Given this list of marker genes IDE, VTRNA1-3, POLR2J3, RNA5SP181, SERTAD4, PDE4B, PROSER3, BORCS5, PPP2CA (NCBI Gene Id 5515), BVES, POLD1, BEST1, CD84, SLC25A20, RNU6-622P, HMCN1, NAALAD2, OR2F1, LTBP4, LINC02426, TMEM147-AS1, FUT6, GAS2L3, PTK2, CPVL-AS2, CYP2AC1P, ERCC6, ANKRD28, TMEM17, ANKRD16, KRT222, CSNK1G1, SLCO6A1, CPD, MIR3912, TSPAN17, DNAJB6, STARD6, RAB37, ACHE, PILRA, GPSM2, NLRP2, RIN1, SLC7A4, NUP210L, USP32, SHCBP1, DYNLT2, APP, VPS26C, FAM204A, ZNF407, LRRC23 (NCBI Gene Id 10233), DCTN4, RPL36AP20, FBL, ELOCP18 (elongin C pseudogene 18), COL16A1, ARL16, BDNF, GPI, SH3BP2, SHARPIN, MT-ND4L, SMARCD2, PPP4R1L, SNCA, MIR5087, RHOBTB1, KRT17, ABCB9, XPA, NEK3, C5orf58, NDUFB3, FLII, RNU6-464P, CD2AP, HSH2D, ZNF292, CTPS1, SGIP1, SCARF1, CD63, FEM1B, PPP1R15A, LRRC34, RPL29P2, SLC39A13, CTNNA1, RC3H2, RAB31, DSG4, LOH12CR2, PDLIM1, MT-TR, RUSC2, SLC7A11-AS1 (SLC7A11 antisense RNA 1), HSF5, RPS11, ACTN2, RGS8, SCTR, CCDC185, RPL10P13, RPL7P54, NBPF1, MIR6074, MIR4481, TROAP, STRN4, SCIRT, PIDD1, NCMAP, CDK5RAP2, MIR302A, LINC02243, TCEANC, BUD31, CTHRC1P1, CDC42, EIF3K, ZNF223, TSEN54, MEF2C-AS1, SNORA61, PRKN (NCBI Gene Id 8004), WFIKKN2, GSG1L, POLK, ENSG00000261924 (novel transcript, antisense to RPTOR), H1-5, HIGD1C, YIPF3, SLC25A45 (solute carrier family 25 member 45), KLC4, CTBP2, TIE1, MAN2A2, MLST8, MRPL58, TMEM132B, ELOVL6, ALAS1 (5'-aminolevulinate synthase 1), RBFOX2, ZNF322, IGHVII-44-2, ITGB4, SCAF8 (NCBI Gene Id 22828), RNU6ATAC38P, TIGD2, FTCD, NUP85, RAD23A, LINC00343, ZNF461, DPF1, ENSG00000260378, ENSG00000221332, CLIC5, POLR2I, USP11, ZNF17, TRAV6 (NCBI Gene Id 6956), CCND2, MYO19, LINC01886, MIR367, MICAL3, UBA5, CNNM1, STAG3, UBE2V2, PRR29-AS1, LINC01614, PPP1CC, GPR183, TPH2, PLD1, ELMOD2, RN7SL284P, C19orf47, NR2C2, BACH1-IT2, DQX1, LINC00534, CPSF3, ANXA4, RFT1, ZNF320, FMR1-IT1, TMEM86A, TROAP-AS1, NT5C2, UBAP2L, GNLY, MT-ND4, BLVRB, UTP6, UFSP2, CFAP298, HNRNPA1P18, DNAJC8, MYO1E, CHCT1, SSBL2P (small RNA binding exonuclease protection factor La like 2, pseudogene), RNVU1-22, TMEM44, UBB, IRF5, MAZ, AKR1B1P7, CRAT, CREB3, MIR641, GJC3, SPX, PHB2P1 (NCBI Gene Id 650109), BNIPL (NCBI Gene Id 192667), HNRNPH1, DPP8, LTBP2, VCF2, ADRA2A, MYRIP, CNOT8, TNFAIP6, ZNF225-AS1 (NCBI Gene Id 100379224), SLC5A9, DBNL, TOMM40L, SUPT20H, FAM184A, B4GAT1, CLYBL, RNU7-80P, NFATC4 (NCBI Gene Id 4776), ACAD9, STARD13, RNA5SP112, PRDM16, EMD, AGPAT4, ENSG00000204117, HDAC8, EHMT2, MED15, TAFA2, RPS5, SNORD116-3, PKN3, ANO10, AOAH, CD2BP2-DT, SNORA70, ADD1, MTATP6P31, MIR545, GSK3A, FAM3B, DDX39B, ATF7IP2, MAP3K7CL, ZNF646, EGLN2 (NCBI Gene Id 54750), GFRA3, NFASC, RPL10, NEUROG3, SLC24A1, CABP1-DT, EML2, SFI1, MIR4466, RPS3AP4, SDCCAG8, CABYR, RPL17P50, RGL2, LAMTOR3P1, CUZD1, PARP6 (NCBI Gene Id 56966), RNU6-481P, MYCBPAP, GTPBP2, KDM2B, PCK1, PLEKHG2, RN7SKP132, PGBP, PTGES3L-AARSD1, TNNT2, ENO1, PTPRB, DEGS2, CERK, FABP5P5, ZNF593 (NCBI Gene Id 51042), CALML6, WDR26, PTCD3, PELATON, MIR548AP, RNA5SP307, MAP4K5, SNRPGP11 (small nuclear ribonucleoprotein polypeptide G pseudogene 11), BMP1, DLGAP1-AS3, ZNF284, NCF4, CREBRF, EAF1-AS1, SEC16B (NCBI Gene Id 89866), DPPA3P3, SLC16A12, LINC00184, TMEM249, NKIRAS1, LDLRAD4, ABCA4, DLG1, TMEM116, SLC35E4, PRSS3, SLC18A1, TRAJ60, SNORA73A, MIR320B2, SLTM, SOBP, PKN1, UBE3AP2, POU2F1, MYLK3, MEF2A, ZNF775, SELENOW, ZBTB17, SERF2, ANKRD26, NCOA4, ATG7, FGF11, RN7SL789P, RNA5SP442 (NCBI Gene Id 106480768), CCR5AS, ATXN2, CYLD-AS1, LINC01344, THY1-AS1, SGCZ, MIX23P5, MFSD5, DTNBP1, MIR302D, TTC39C, ATP5MFP1, SLC17A7 (NCBI Gene Id 57030), TM9SF2, MAD2L1BP, MYEOV, STARD9, PSMC1P10, DRAIC, POLR1C, XPNPEP1, TCEAL6, DHX38, FCHO1, IL13RA2, STAT3, CEACAM4, CCNE1, IGHV3-30-2, NPM1, UQCRBP2, ICMT-DT, PBRM1, RGS6, CD27, USF1, SLC9A5, MIR302C, FAM180B, MYCBP, RNU6-1039P, SNRPA, KLC1, PLCE1P1, NKX1-2 (NK1 homeobox 2), TARID, CASC2, TECR, FCGR2A, B4GAT1-DT (B4GAT1 divergent transcript), PTGES3L, RPS6KA6, WNT11, RPL23AP72, AZIN2, CLEC1A, MT-TF, TRPV2, DNM1, CYP2E1, FMR1, MIR6783, RNU6-1019P, RNU1-133P, YWHAH, MRPS31P5, METTL17, SLC25A19, HMGN2P46 (high mobility group nucleosomal binding domain 2 pseudogene 46), FNDC11, GPC5-AS1, IL24, ELF3-AS1, USP54, RPL35AP36, MIR1268A, SNORD123 (small nucleolar RNA, C/D box 123), CHORDC1P4, C1orf232, TTLL4, RHEB, RNA5SP493, CGRRF1, ITGB3BP, RNU6-1115P (NCBI Gene Id 106480639), DYRK2, RPS27P7, C11orf58, SNORD114-25, SYNGAP1, SARDH, TMEM190, METAP1D, NACA, FAM114A2, LINC02312, POU3F2, CPAMD8, FCSK, SPPL3, CT62, DNAH14, GNAS, ENSG00000207502, RNU6-864P, SDS, RNU6-808P, BCAS3, MIR4480, VANGL1, TANC1, HDDC2, HRG-AS1, NPM1P26, RP1L1, LINC01485, DNMT1, GNG4, MN1, METTL15, SNORD114-7, ENSG00000215156, KLHL31, ST7L, AFTPH, SGPL1, IFT56, DGKA, GIPR, SRGAP3, LINC01794, EVI5L, CYTH1, POLR2A, PITX1, CDIP1, MAP3K5-AS1, DNM3, FCGBP, PHLPP2, DDX3P2, B2M, MTCO3P12, UCK2, AKAP4, SEMA3E, CTSS, IGDCC4, KPNB1, GPC5-IT1, CIB2, CNIH3, PTK2B, PLSCR3, CHFR, PCDHGA9, MIPEPP3 (mitochondrial intermediate peptidase pseudogene 3), LINC00910, BABAM1, DNAJC16, LRRC37A16P, GRB7 (NCBI Gene Id 2886), MOK, ALS2CL, SAFB2, ZNF540, GP6-AS1, CEACAM6, UBXN6, IFNA4, RYR2, PPT1, FBXO17, MIR4322, RNU6-607P, HNRNPA3P3, RPRD1B, SEZ6, IGF2R, ZCCHC7, DENND3, POU2F2, TMEM138, CHUK, BEND6, SUNO1, TAS2R4, FUS, PHKG2, RNF213, KRT15, NT5DC3, LAT, MMP3, EDRF1-DT, KALRN, SEC23B, ABCC10, HR, MIR300, BDKRB2, ZNF625, BRCA2, IGLVVI-22-1, NEURL4, EIF4B, XPO5, EXOC4, OGFOD2, RAD54B, NDUFA3P4, ACTMAP, ABHD1, RPL10P14, TMEM54, POLR3G, TRPV5, ZNF16, TRMU, SYCP2L, STAG3L4, TJAP1, FOXP1 (NCBI Gene Id 87246), PRKACB, SNORD7, PLK3, TRAJ61, HNRNPH3, PRKCE, IGHVII-28-1, KRTAP9-6, SLC25A39P1, SMARCE1P1, IGLV2-33, CCNL1, TNXB, RRN3, RNU6-992P, NAPB, C16orf92, SKIC2, FRMPD3-AS1, HNRNPL, MAPT (microtubule associated protein tau), GMEB2, ADAMTS6, COQ8B, VDAC1P13, RUFY2, TM2D3, RN7SL524P, TMEM268, NGRNP2, ENSG00000248994, ITGAL, PDCD6IP, S100A4, MIR3194, CFAP119 (cilia and flagella associated protein 119), AKT2, INO80D-AS1, PCDH7, STXBP5-AS1, PLD3, AP1M2P1, TOR3A, MVB12A, TFRC, BACE1, RTN4IP1, SLC39A3, PKM, LINC02537, TENT4B, CARS2, NUP214, CR1L, NPR2, SRCAP, SEC13, MAP3K10, SPACA7BP, OLIG1 (NCBI Gene Id 732056), DYNC1I1, OR9R1P, ARHGAP15-AS1, MIR1321, ITGB2, LRRC75A, COPS7B, KCTD15, AP1B1P1, MGAT5, TMEM121, PLPPR4, DOCK5, MIR4645, RUFY1, UBDP1, GPCPD1, GPHB5, EGFLAM-AS2, CC2D2B, RNPS1 (NCBI Gene Id 10921), MROH8, MIR1271, ZSWIM4, ENSG00000252404, COX11P1, EPN2, RUNDC1, RNFT1, ACOT7, EIF1AD, THAP8, EXOSC2, RIMKLA, MIR374A, LINC00690, DST, GALNT12, CAMTA1, SHMT1, MIR3153, CDON, TTC39A, LINC02384, BRAP, GRAMD2A, MIR4521, GPR162, AHR, FBLL1, TMEM167A, CRIPTOP4, CCRL2, SNRPA1, ZNF345, CTTNBP2NL, UBE2D3P3, KLRB1, ANKRD34B, REEP3, STK3, DAAM2-AS1, C7, ADAM30, PAF1, ANK2, NFILZ, DCHS2, LMO3, STAU1, DOC2A, CAPG, HEPH, KRT7, RN7SKP67, NAPSA, ABCA2, MSI2, RNF10, PPEF1-AS1, LINC00665, GATAD2B, ARRB1, RUNX2, ZSCAN29, LINC01999, MTCO3P31, RAB34, MDC1, GUSBP18, MIR9-3HG, PDE8B, REC8, CIDEA, ARHGAP26, LINC01803, PIK3C2B, VASH2 (vasohibin 2), MIR6782, RNU5F-7P, FLNA (NCBI Gene Id 8272), TUBGCP4, ZNF497-AS1, CLEC16A, SKOR1, SMARCD3, ENSG00000260660, ZNF573, TIGD6, RPS29P7, SEPTIN11, AP5S1, CEP44, PPP1R10, ENSG00000230190, CADM3, TMEM219, CFAP97P1, NRAD1, HAUS5, LNCEGFL7OS, MIR4460, TTI1, STING1, LMBR1, PGBD4P6, RN7SKP219, PPP1R12B, SLC25A17, ABCC11, MLF2, THEM7P, MUC22, ENSG00000246477, GLUD1P2 (glutamate dehydrogenase 1 pseudogene 2), MYBPC1, PHF7, RRAGC-DT, MIR4725, PLEKHA7, ADAM11, TACC1, SETP15, SLC35B1, HEXD, RPL23AP58, IL31RA, YJU2, CD164, UBFD1, SPC25, MIR3976, DCD, SPTBN4, CD46P1, RCAN3, TNKS, RNU1-75P (RNA, U1 small nuclear 75, pseudogene), FRG1HP, RNU6-1015P, TRAF3IP3, POU2F3, CASKIN2, CXXC5, UNK, TXNRD2, ZAR1L, LGI4, ATP9B, ARID4B, BMS1P1 (NCBI Gene Id 728053), CFAP144P1, PXN, DPEP1, RNA5SP38, WT1, RSF1-IT1, RPL11, CBX5, SHANK2, SLC13A3, ADORA2A, PRRG3 (proline rich and Gla domain 3), MMS22L, TRAV8-6, SNX2, PTPRF, IPPK, RPS27AP3, GABARAPL3, CSPG4, MED18, PWP1, MAP4K1, NCOA7, WT1-AS, EGFL8, ANKRD13A, U2AF1L4, SLC9A3P3, TMTC1, SLC25A6, HNRNPR, ABR (ABR activator of RhoGEF and GTPase), CYP2C8, ATP7B, TNIK, BANF1, GON4L, TRIM23, EXOC5P1, CDK2AP1, RNA5SP260, FAM230G, TMEM202-AS1, LINGO1, RNU6-820P, RPH3AL, SPEN (NCBI Gene Id 348488), PAX6, DMPK, LINC02529 (long intergenic non-protein coding RNA 2529), CREBBP, RAB11FIP4, ARPC2, UBA52P8, CTSB, RANGRF, AARSD1, WIZ, MIR365BHG, SET, KRT18P60, NOL4, CHMP6, MIR6068, USP7, DAAM2, RNU6-419P, TEX101, MCRS1, ZNF101P1, PLXDC1, POMT2, GCNT3, KLK1, LINC01623, ENSG00000262231, MIR9-2HG, MIR6796, TRIM24, HYCC2, KEAP1, MIR3173, TUBA8, TDRD9, HNRNPDP2, ACAA2, ALKBH5 (NCBI Gene Id 54890), ERICH3, MDM2 (NCBI Gene Id 84825), RBM28, CCN6, ST3GAL5, MACF1, CYBC1, DYNC1LI2, RPL21P115, TNPO2, KPNA4P1, CC2D1B, ATP1A4 (ATPase Na+/K+ transporting subunit alpha 4), MAP3K21, MIR302CHG, LONRF1, TMEM14C, LIPG, CFAP96, KPNA3, CLDN14, FAM81A, FAM215A, CACNA2D1, COL24A1, SAT1, RPS5P7, DPH7, CA7, MT-RNR1, TAS2R6P, DNAJA1, NEFH, LGALS3BP, IQCH-AS1, KDM3A, CSF2RA, HGS, TMEM98, SMAD5, TUFT1, PLOD3, ACACA, PDZD2, SNCA-AS1, XPO6, here is a description of the gene set: studied in species Homo sapiens from publication Yevshin I, Sharipov R, Kolmykov S, Kondrakhin Y, Kolpakov F (PMID 30445619) Human Gene Set: SMN1_SMN2_TARGET_GENES Genes containing one or more binding sites for (SMN1 or SMN2) in their promoter regions (TSS -1000,+100 bp) as identified by GTRD version 20.06 ChIP-seq harmonization.